The following is a description of a gene set: species: Homo sapiens BACKGROUND: Studies suggest that the recall-based humoral immune responses to influenza A/H1N1 originates from activated memory B cells. The aim of this study was to identify baseline, early and late blood transcriptional signatures (in peripheral blood mononuclear cells/PBMCs) associated with memory B cell response following influenza vaccination. METHODS: We used pre- and post-vaccination mRNA-Seq transcriptional profiling on samples from 159 subjects (50-74years old) following receipt of seasonal trivalent influenza vaccine containing the A/California/7/2009/H1N1-like virus, and penalized regression modeling to identify associations with influenza A/H1N1-specific memory B cell ELISPOT response after vaccination. RESULTS: Genesets and genes (p-value range 7.92E(-08) to 0.00018, q-value range 0.00019-0.039) demonstrating significant associations (of gene expression levels) with memory B cell response suggest the importance of metabolic (cholesterol and lipid metabolism-related), cell migration/adhesion, MAP kinase, NF-kB cell signaling (chemokine/cytokine signaling) and transcriptional regulation gene signatures in the development of memory B cell response after influenza vaccination. CONCLUSION: Through an unbiased transcriptome-wide profiling approach, our study identified signatures of memory B cell response following influenza vaccination, highlighting the underappreciated role of metabolic changes (among the other immune function-related events) in the regulation of influenza vaccine-induced immune memory. Genes negatively correlated with memory B cell response at 28d in peripheral blood mononuclear cell in seniors (50-74) after exposure to Fluarix, time point 0D from publication Haralambieva IH, Ovsyannikova IG, Kennedy RB, Zimmermann MT, Grill DE, Oberg AL, Poland GA (PMID 27317456) Human Gene Set: HARALAMBIEVA_PBMC_FLUARIX_AGE_50_74YO_CORR_WITH_28D_MEM_B_CELL_RESPONSE_AT_0DY_NEGATIVE, and this is the list of marker genes: LRRC58, REL, GRIK5 (NCBI Gene Id 2901), PI4KAP2, GPM6B, FUT4, SLC2A9, SDCCAG8, ANO8, CBX6 (chromobox 6), PIAS4, RELB, ATP6V1F, LRRC59, KLF10, ZFP91-CNTF, CSNK1A1P1, WBP11P1, GALNS, PELI2, ENPP2, CIDEB, ZNF487 (zinc finger protein 487), RHEX, ZNF703, PHKA2, PIP5K1B, KLF4, SGK3, CXXC5, WDR17, OGFRL1, KRT23, KPNA3, AP5B1, RNF217, ZDHHC7, TMEM170B, TMTC2, DENND1A, SRRM2, SAMD1, ALDH2, EIF4H, IFT20, CAMK1D, ARHGAP24, KHSRP, MLX, CDA, ZNF503, SDCBP, OAF, GTF3C4, CLEC4C, NRIP1, CXCL8, BMI1, SCPEP1, SUMO1P3, ST20-AS1, RAB11FIP2, MED25, ZFP91, GOLIM4, PTGS2, PPTC7 (protein phosphatase targeting COQ7), DHX40, TMEM183A, VENTXP7, NINJ1, TRAM2, WDFY4, MAPK6, SERINC1, SLC9A7, NAB2, PTENP1, SNX29, LTA4H, NEU3, ZMIZ1, GNA15, PXK, KLHL8, ZBED3, MAP1LC3B2, ACO2, SRGAP2B, PSMD3, LINC02908, ASAP1, RNPEP, ZNF697, TSNARE1, FSCN1, ZNF426, RPL7L1, GRINA, LILRA4, TNFRSF21, ZNF791, DOCK4, CLDN23, PRKACG, UCHL3, NPEPL1, GAS7 (growth arrest specific 7), DCUN1D1, GANC, GAB2, ANO10, TMEM150B, IL18, SYK, KLF7, LENG9, N4BP2, SLC38A7, FCHSD2, LRG1 (NCBI Gene Id 116844), TMED7, PANK3, ZFAND3, IER2, MTX1, EME2, GINM1, JUN, TTC3P1, MEF2A, STS, PI4KA, HINT3, SLC15A3, VIM, LGR4, SPI1, PRKAR2A, PLAGL1, P3H2, SPOPL, PPP2R5B, WDR5CP, AJAP1, GUCY2D, ZFP36, IDH3A, WASHC2A, NUDT17, IGBP1P1, MID1IP1 (MID1 interacting protein 1), CREB5, PISD, TM9SF2, HNRNPH2, SFT2D2, FAM168A, MROH1, RFX2, TMED7-TICAM2, MAPRE1, SCML2, CUX2, SCARB1, ST6GALNAC3, NRROS, ROGDI, MAP2K7, BOP1, RIN3, APP, ARF1, ENSG00000293358, HLA-DMA, SLC16A5, ARID3A, STX10, NATD1, VEGFA, MAP3K3 (NCBI Gene Id 4215), PIK3CB, CDC42EP1, P2RY11, SLC30A1, GRAMD1B, GMEB1, DNAJC11, C19orf38, POM121, GNL2, SMAP2, RRAGC, TNFRSF10B, KIF13A, BCL6, FAM151B, FAAH, DERA, UBE2MP1, PNPLA2, WASHC2C, EPHX1, PAPLN, CCNYL1, CHPT1, DYM, PPP4R2 (protein phosphatase 4 regulatory subunit 2), PABPC3, DYSF, SPEN, GLIS3, MAP3K21, JAG1, RDH14, PJA2, CRISPLD2, ERC1, CDKN1A, ASAH1, TRIO, KIAA1958, BLTP3B, SPRED2, RNF130, SCT, NCF1, C2orf49, ADGRA2, NUBP1, TMEM86A, CCDC186, RNASEK, ZFP92, TBC1D9, BAHCC1, MTCL2, CLPB, DTX2P1-UPK3BP1-PMS2P11, ABITRAM, MICAL2, BRI3BP, HSF1, OLIG1, ASCC2, ABCB7, RIPK2, RNF24, CTAGE7P, RSC1A1, SETD7, GMFB, MOB3A, ATP11C, BACH1, TUBGCP3, BNIP3L, CEP170, G0S2, TYROBP, VRK2, ITPRID2, BCL2L2-PABPN1 (BCL2L2-PABPN1 readthrough), TET3, PLEKHM3, RASSF4, SLC12A6, KCNK17, CD300C, PLBD1, TRIM8, MRPS22, NFIC, RNF6, CSNK1A1L, LYZ, KCTD3, RPS6KC1, KCNC3, TECPR1, MLXIP, BLTP3A, SULT1B1, YPEL2, TIFAB, SIGLEC6, SCAMP5, MARVELD1, SHANK1 (NCBI Gene Id 50944), TMEM144, ATP6V0C, PLEKHM2, CLEC6A, EPHA2, PABPC1P2 (NCBI Gene Id 730694), GATAD1 (NCBI Gene Id 79636), PEMT, GPATCH2L, COA7, ENSG00000272447, NAB1, CSDE1 (cold shock domain containing E1), PAK1IP1, TOR1AIP1, S1PR3, SCAMP2, USP6NL, AHNAK2, ZNF496, RAB20, LIN7A, GAS2L3, CEBPD (NCBI Gene Id 1052), PXDC1, MEMO1, PANX2, RNASE2, CCDC88A, CERS6, TCF4, CADM4, MPP7, BNIP2, NRP1, RSRC1, LGALS8, PGAM2, OPN3, SLC22A4, TMTC1, ANAPC15, ATP1B1, APOM, CCDC86, AP3B1, KAT5, SERTAD2, TBC1D12, ZNF385A, MOB1A, NUDT3, NUP58, IRF8, ERCC5, CCDC6, SNX12, CCDC50, NIPSNAP2, EIF2AK2, LRRK1, UGGT2, GLUD2, TFE3, GPR157, LDLRAD3, PLXDC2, CDK8, TTC7A, CCDC47, WLS, EIF4E2, ZNF689, XXYLT1, TLNRD1, SCN9A (NCBI Gene Id 93955), ZNF511, HTR7P1, DSG2, MTMR14, GNAQ, RARA, NFIL3, MACF1, MKNK2, PSMB7, ADAM17, PLEK, OCRL (NCBI Gene Id 4952), MKRN10P, DACH1, MME, ZNF768, FRRS1, KSR1, SERPINF1, ZNF281, STRN4, SH3BP4, AOAH, SLC36A4, INCENP, PCDHGC3, CIITA, HLA-DMB, ARL8A, PPM1J, CEBPB, UGCG, YBX3P1, TXNDC5, NEK6, SMARCD3, NCOR2, RAB5C, CHML, SYS1-DBNDD2, TSPAN16, SMARCB1, MAN2A1, SNX2, CDC40, NKIRAS2, ZFAT, LTB4R2, KCNQ1, RIC1, MBD6, ZNF844, MAPK7, ATP6V0B, TBC1D14, GNA11, RRM2B, AZU1, RREB1, NETO2, TMEM39B, MKRN9P, TPCN1, HLA-DRA, INO80B, MED13L, LRRC4, PEAK1, ELOF1, MAML3, DENND5A